The following is a description of a gene set: Human Gene Set: GOMF_HAPTOGLOBIN_BINDING species: Homo sapiens Binding to a haptoglobin, any alpha2 globulin of blood plasma that can combine with free oxyhemoglobin to form a stable complex., and this is the list of marker genes: HBB, HBE1, HBG2, HBD, HBM, HBA2, HBZ, HBA1, HBQ1, HBG1